Given this list of marker genes Cmpk2 (NCBI Gene Id 80594), Dut, Tbpl1, Tyms, Dctpp1, Dtymk, here is a description of the gene set: studied in species Mus musculus The chemical reactions and pathways involving pyrimidine deoxyribonucleoside triphosphate, a compound consisting of a pyrimidine base linked to a deoxyribose sugar esterified with triphosphate on the sugar. Mouse Gene Set: GOBP_PYRIMIDINE_DEOXYRIBONUCLEOSIDE_TRIPHOSPHATE_METABOLIC_PROCESS